The following is a description of a gene set: Parietal bossing species: Homo sapiens Parietal bossing is a marked prominence in the parietal region. Human Gene Set: HP_PARIETAL_BOSSING, and this is the list of marker genes: RUNX2, PTPN11, FIG4, POLR3A, MPDU1, KRAS, PTCH1, FGFR3